The following is a description of a gene set: Human Gene Set: GOBP_RIBOSOMAL_LARGE_SUBUNIT_BIOGENESIS species: Homo sapiens A cellular process that results in the biosynthesis of constituent macromolecules, assembly, and arrangement of constituent parts of a large ribosomal subunit; includes transport to the sites of protein synthesis., and this is the list of marker genes: RPL5, RPL7A, RCC1L, WDR74, RPL26L1, MIURF, RPL14, RPF2, ZNF622, DDX18, RRS1, MDN1, DHX30, TRMT112, RPL24, GTPBP4, NOC2L, RPL26, NSA2, MRTO4, MAK16, MTG1, FTSJ3, FASTKD2, EIF6, GTF3A, TMA16, BRIX1, NLE1, SDAD1, AFG2A, RBM34, URB1, RRP15, NOL9, LTO1, NOP16, NOP53, ZNHIT3, CINP (cyclin dependent kinase 2 interacting protein), PAK1IP1, LAS1L, NIP7, DDX28, MTG2, BOP1, RPL35A (ribosomal protein L35a), EBNA1BP2, AFG2B, RSL24D1, AIRIM, MRM2, NPM1, RPL7, RPL10L, MALSU1, RPF1 (NCBI Gene Id 80135), ZNHIT6, PES1, SURF6, HEATR3, RPL7L1, RPL35, WDR12, PPAN, NVL, RPL11, NOP2